Given this list of marker genes Gna15, Gng10, Gna14, Gna11 (NCBI Gene Id 327779), Gngt2, Gng3, Gng5, Gnb4, Gnb1, Gnaq, Gngt1, Aamp, Gng13, Gnb2, Gng11, Gnb5, Gnb3, Tbxa2r, Gna13, Gng4, Gng8, Gng2, Gng7, Gng12, here is a description of the gene set: Thromboxane signalling through TP receptor species: Mus musculus Mouse Gene Set: REACTOME_THROMBOXANE_SIGNALLING_THROUGH_TP_RECEPTOR